The following is a description of a gene set: studied in species Mus musculus Any process that modulates the frequency, rate or extent of the chemical reactions and pathways involving lipids. Mouse Gene Set: GOBP_REGULATION_OF_LIPID_METABOLIC_PROCESS, and this is the list of marker genes: Abcd1, Pik3cg, Fshb, Ggcx, Id2, Wdtc1, Fabp1, Igfbp7, Fgf21, Kat5, Mup1, Drd3, Lpcat1, Dcaf5, Zfp69, Lep, Adipoq, Phb2, Tmx1, Dhcr7, Nr1d1, Hrh1, Insig2, Tysnd1, Mapk1, Ncor1, Gnb3, Pnpla2, Scp2, Clcn2 (NCBI Gene Id 404589), Sphk2, Fabp3, Pde3b, Sirt3, Bmp5, Hsd3b4, Samd8, Ccn1, Irs2, Endou, Rubcnl, Ephx2, Idi2, Cyp7a1, Rptor, Aadac, Gpam, Akt2, C1qtnf2, Prkaa2, Crebl2, Acer1, Nfkb1, Golm1, Angptl4, Cpt1a, Apoa4, Capn2, Star, Npy1r, Plin5, Ormdl3, Hsd3b8, Rdh16f2, Ccdc3, Sik1, Mtmr1, Dgat1, Eed (embryonic ectoderm development), Agt, Sirt6, Ddx20, Acacb (NCBI Gene Id 97267), Kit, Thrb, Cers2, Abcg1, Pla2g3, Nr5a2, Apoe, Mir214, Nsmaf, Il1a, Pibf1, Psap, Scap, Sirt4, Lhcgr, Smpd3, Tpk1, Fmo5, Abhd5 (NCBI Gene Id 69842), Mboat7, Dnajc19, Acadvl, Sct, Stard4, Fgf1, Slc22a13, Plcg2, Sirt1, Cnep1r1, F2 (coagulation factor II), Dkk3, Ubr4, Insig1, Sec14l2, Ncoa2, Ins1, Acsl5, Enpp7, Tcf7l2, Dab2, Klhl25, Foxa2, Kcnma1, Snai1, Sik2, Apobec1, Gpr39, Gper1, Nucb2, Bckdk, Daglb, Rdh10 (retinol dehydrogenase 10 (all-trans)), Lonp2, Ces1f, Pdgfa, Rest (RE1-silencing transcription factor), Tnf, Pla2g4a, Ces1e, Mlxipl, Gps2, Eef1a2, Rnf213, Crtc3, Mtmr3, Erfe, Gimap5, Angptl3, Igf1r, Pparg, Mup11 (NCBI Gene Id 100039028), Apoc2l, Paqr4, Idh1, Mlst8, Cnr1, Rgn, Aqp8, Ttc39b, Gnai1, Sorl1, Brca1, Arv1, Fmo4, Acsl4, Igf1, Cyp27b1, Adipor1, Obp2a, Pdk3, Ccnc, Hcar1, Prkaca, Abhd6, Rdh19, Ttc39d, Fmc1, Mbtps2, Snca, Ppargc1a, Prkag2, Lpgat1, Zbtb20, Prkce, Disp3, Ifng, Cidec, Sox9, Ormdl2, Gh, Asah1, Rdh1, Mtor, Dgat2, Apob, Mtmr9, Gk, Pex2, Tnfrsf1a, Nr1h3, Fabp5, Fdps, Adora1, Apoc1 (NCBI Gene Id 11812), Fgfr4, Cav1, Prkcd, Paqr3, Rab38, Mup3, Dkkl1, Atg14, Clstn3, Eif2ak3, Tm6sf2, Ces1c, Appl2, Hnf4a, Rora, Arf1, Dgkq, Stub1, Irs1, Lactb, Sorbs1, Nr3c1, Pck1, H6pd, Gfi1, Pdk4, Chp1, Rarres2, Atp1a1, Ogt, Cdk8, Apoa2, Adgrf5, Abca3, Hsd17b13, Avpr1a, Esr1, Akt1, Nr1h4, Abcg4, Creb1, Ces1b, Bbs4, Apoc3, Asxl3, Abcb11, Mlx, Ceacam2, Kat2b, Ins2 (insulin II), Slc45a3, Etfbkmt, Acsl3, Acadl, Bmp6, Avil (advillin), Pank2, Pla2g6, Adora2b, Rorc, Rack1, Lsr, Tbl1xr1, Sirt2, Ormdl1, Wnt4, Gpld1, Stat5a, Ch25h, Macroh2a1, Por, Mtmr4 (NCBI Gene Id 170749), Apoa5 (apolipoprotein A-V), Mlycd, Hsd3b9, Akr1c18, Rdh16, Mid1ip1, Prox1, Thra, Slc27a1, Tspo, Ptgs2, Hpgd, Bmp2, Fmo1, Ldlr, Avp, Nfe2l1, Armc5, Ppard, Pgk1, Gprc6a, Adgrf1, Hcar2, Prkg1, Srebf1, Cyp17a1, Apoh, Hsd3b5, Sf1, Apod (apolipoprotein D), Ces1h, Psapl1, Dhh, Anxa1 (annexin A1), Snai2, Il1b (NCBI Gene Id 16176), Serpina12, Gpr146, Cga (NCBI Gene Id 12640), Mir199a-2, Mapk9, Pcx, Trib3, Spata18, C3, Ces1g, Lpcat3, Ces1a, Gip, Ceacam1, Adra2a, Htr2c, Twist1, Dbi, Srebf2, Abca2, Pdk1, Prkaa1, Cd74, Trex1, Chrm5, Zmpste24, Stat5b, Fgf15 (NCBI Gene Id 14170), Atg7, Erbb4, Abcd2, Egr1, Mup5, Gal, Isx, Pde8b, Htr2a, Mtln, Cidea, Apoc2, Pdgfb, Ppara, Dnajc15, Ctdnep1, Sctr, Erlin2, Gimap3, Nr1d2, Elovl5, Ankrd26, Zfp750, Trem2, Ghsr, Nr1h2, Apoa1, 3110082I17Rik, Mup2, Bglap2, Igf2, Malrd1, Fmo2, Pdk2, Bcl11b, Sphk1, Mtmr2, Alk, Opa3, Mup4, Prmt3, Bglap, Erlin1, Mfsd2a (NCBI Gene Id 76574), Scarb1, Ces1d, Bscl2, Eif6, Abca7, Htr2b, Gdf15, Cmtm2a, Thrsp, Sod1, Nr0b1, Lmf1, Rdh9, Qki, Angptl8, Cideb